Given this list of marker genes PASK, CYP2J2, CCDC141, FOXP1, APBB1, TECPR1, MCF2L-AS1, ACVR1C, DSC1, ZIK1, HLA-DOA, GP5, EXD2, NT5E, PRKAG2-AS1, KLHL32, ATG9B, NOG, RAI2, GFOD3P, CNKSR2, USP51, C10orf95-AS1, TWNK, KLF7, CFAP68, PRKCA, ZNF223, HAUS5, CA6, PTPRK, TMEM243, SH3RF3, GPRASP2, MAN1C1, ALDOC, CARS1, IL6ST, CD248, SULT1B1, TCF3, SNHG29, CHCHD7, SLC2A11, DDX31, AGBL2, ZNF404, SFXN2, TNFRSF10D, REPIN1, NDFIP1, LAPTM4B, TSEN2, UBE2E2, ZNF629, OXA1L, SCML1, ZNF22-AS1, MDS2, RGS10, ST13, RNF175, SCOC-AS1, EBPL, MEST, FBLN2, PDE9A, RFX2, SPINK2, SLC12A6, HSBP1L1, NRCAM, ADPRM, DCHS1, LEF1-AS1, ZCWPW1, PLPP1, COQ8A, RMND5B, OXNAD1, ARHGAP32, ZNF512B, ROBO3, MICU3, SUSD3, SCARB1, ZNF496 (zinc finger protein 496), BEND5, LAMP3, YPEL2, ERICH1, GNAS-AS1, RPL14, ABCB8, LEF1, AGMAT, LRRN3, TYSND1, OBSCN (NCBI Gene Id 84033), FAM184A, FAM117B, LAYN, TAF4B, PIK3IP1, MMEL1, LEPROTL1, ATP6V0E2-AS1 (NCBI Gene Id 401431), TBXA2R, SREBF1, DICER1-AS1, FAHD2A, CLEC11A, DENND5A, BDH1 (3-hydroxybutyrate dehydrogenase 1), CHMP7, IKBKE, IGF1R, NAT9, RPL5, PDK1, TTC9, EFHD1 (NCBI Gene Id 80716), EEIG1, FCGBP (NCBI Gene Id 8857), SOX8 (SRY-box transcription factor 8), SP2-AS1, ZNF285, RETREG1, ZDHHC9, ZNF662, NREP, SLC8B1, SLC16A10 (NCBI Gene Id 55457), ZWINT, PIK3CD, BPHL, SNED1, VIPR1, PLEKHG4, TPST1, TMEM220, GAL3ST4, ARMCX1, MRPS25, ZNF436-AS1, APEX1, ARHGEF4, CDCA7L, TRABD2A, FLNB, ADGRA3, TMEM272, MANSC1, FOXO1, USP20, ECRG4, ACTN1, CD9, KIAA1958, BEX3, PDCD4-AS1, EDAR, UBIAD1, NAA16, AMIGO1, CR2, LDLRAP1, SPINT2, ZNF844, ACSS2, GAS5, SERINC5, PRRT1, FAM241A, MTA3 (NCBI Gene Id 731342), PRKCQ-AS1, COPG2IT1, EPHA1, CDK20, FBXO15, ZNF667-AS1, CBR3, THYN1, PLAG1 (PLAG1 zinc finger), RPL27, MAL, SFXN4, RAB43, TACC3 (transforming acidic coiled-coil containing protein 3), ARMH1, SNHG32, RNF157-AS1 (RNF157 antisense RNA 1), COQ3, COL6A3, PRXL2A, here is a description of the gene set: T cell dysfunction is an important feature of many chronic viral infections. In particular, it was shown that PD-1 regulates T cell dysfunction during chronic LCMV infection in mice and PD-1 high cells exhibit an intense exhausted gene signature. These findings were extended to human chronic infections such as HIV, HCV and HBV. However, it is not known if PD-1 high cells of healthy humans have the traits of exhausted cells. In this study, we provide a comprehensive description of phenotype, function and gene expression profiles of PD-1 high versus PD-1 low CD8 T cells in the peripheral blood of healthy human adults as following: 1) The percentage of naive and memory CD8 T cells varied widely in the peripheral blood cells of healthy humans and PD-1 was expressed by the memory CD8 T cells. 2) PD-1 high CD8 T cells in healthy humans did not significantly correlated with the PD-1 high exhausted gene signature of HIV specific human CD8 T cells or chronic LCMV specific CD8 T cells from mice. 3) PD-1 expression did not directly affect the ability of CD8 T cells to secrete cytokines in healthy adults. 4) PD-1 was expressed by the effector memory (TEM) compared to ‘terminally differentiated effector’ (TEMRA) CD8 T cells. 5) Finally, an interesting inverse relationship between CD45RA and PD-1 expression was observed. Genes up-regulated in comparison of naive CD8 T cells versus PD-1 low CD8 T cells. from publication Duraiswamy J, Ibegbu CC, Masopust D, Miller JD, Araki K, Doho GH, Tata P, Gupta S, Zilliox MJ, Nakaya HI, Pulendran B, Haining WN, Freeman GJ, Ahmed R (PMID 21383243) Human Gene Set: GSE26495_NAIVE_VS_PD1LOW_CD8_TCELL_UP studied in species Homo sapiens